The following is a description of a gene set: Each fraction of mouse hematopoietic cells was purified by cell sorting from bone marrow of 8-week-old C57BL/6 mice, and its gene expression was analyzed. studied in species Homo sapiens from publication Konuma T, Nakamura S, Miyagi S, Negishi M, Chiba T, Oguro H, Yuan J, Mochizuki-Kashio M, Ichikawa H, Miyoshi H, Vidal M, Iwama A (PMID 21540074) Human Gene Set: GSE27786_CD8_TCELL_VS_MONO_MAC_DN Genes down-regulated in comparison of CD8 T cells versus monocyte macrophages., and this is the list of marker genes: SCCPDH, FBXO34, IL18BP, LRRC8D, WBP2, MIR22HG, MCF2L, SETD1B, PPP1R2P1, CDK11B, DTX4, B3GNT8, LHFPL2, PHF10, CORO7, FARP1, GOLGA2, GPC1, ARHGAP23, ZNF384, CLTA, MED31, NDC80, TIPIN, PDZD8, SLC8B1, HJURP, CLEC10A (C-type lectin domain containing 10A), ARAP3, GPR137B (G protein-coupled receptor 137B), SMC1B (NCBI Gene Id 27127), ATXN1L, POC1A, HSBP1L1, MPC2, AGTPBP1, NAA38, FAM217A, CDKN1A, PGAM1, MREG, SGK3 (serum/glucocorticoid regulated kinase family member 3), TIRAP, P2RX4, VASP, PI4K2B, DMD, CCNYL1, KIF20A, DPY19L4, MYO1D, ETFRF1, MRTFA, ARHGEF25, LANCL2, ZC2HC1A, OXSR1, LXN, CCDC34, TSPOAP1, TIMP2, GORASP1, TRAPPC10, SPOCK2, HRG (histidine rich glycoprotein, NCBI Gene Id 3273), ABCD3, MRAS, COX19, TMEM179B, CPEB4, MAF, CYFIP2, KCNMA1, PALM, USP5, OSER1, RALGAPA1, EME1, TPPP3, NFYA, MFSD12 (NCBI Gene Id 60369), TYMS, DIO2, CRYZL1, AMPD2, NR5A1, CDK2, BATF2, EHD1, TRAPPC2, AP3S1, MAML1, GXYLT1, FOXI1 (NCBI Gene Id 2299), CLCN5, KCTD10, TNRC18, SEM1, EXOC1, CWH43, DNAAF9, TBC1D31, N4BP1, CHRNA9, NME8, CACNG4, MYBPC1, RNF182, MASTL, CACNG2, C1QTNF9, MIR1915HG, ADCY4, LIMS4, CYB5R4, YWHAH, ACTG2, DMPK, C16orf78, TMX3, ERCC6L, SBNO2, NETO2, GNB5, PLEKHF1, ATP2A3, RAB14, SASS6, CFAP119, ARHGEF26, TTLL11, TRPM2, HSPA4L, TINAGL1, PLPP1, MPP1, KIF20B, PIF1, KIF14, AMDHD2, LAIR1, SLC25A18, GRB10, DHRS1, DHRS13, KRT28, CHIT1, COQ4, LBR, OPTN, SLK, UXS1, NRDC, CYP4A22, CBX5, HOOK3, YAF2, ADAM9, PLA2G15, FOXD4L1, UEVLD, NFIC, SLC48A1, USP15 (ubiquitin specific peptidase 15), EIF4EBP1, MFSD9, MFSD6L, NKIRAS2, SLC22A12, HNRNPLL, ARRB1, HSPB2, OBP2B, MAP3K10, DHX38, C2orf68, SYCP1, ARPC5, ANKRD46, CYP26A1, FHOD3, API5, GADD45B, IRS2, VNN1, PRKAR2A, RDH12, MYL1, ADA, AGTRAP, TACC1, BLVRB, PARD3B, OSBPL8, NDUFAF3, BRD3, BBLN (NCBI Gene Id 95825), LMLN, TSPAN14, LDLRAD3